Given this list of marker genes POLR2D, GTF2H1, POLR2A, GTF2H2, CDK7, GTF2F1, SUPT5H, GTF2F2, RNMT, MNAT1, CCNH, POLR2L, ERCC2, POLR2K (NCBI Gene Id 5440), NCBP1, GTF2H3, POLR2C, RNGTT, ERCC3, POLR2E (RNA polymerase II, I and III subunit E), POLR2J, GTF2H4, POLR2B, POLR2H, POLR2G, POLR2I (NCBI Gene Id 5438), NCBP2, GTF2H5, POLR2F (NCBI Gene Id 5435), here is a description of the gene set: The 5'-ends of all eukaryotic pre-mRNAs studied thus far are converted to cap structures. The cap is thought to influence splicing of the first intron, and is bound by 'cap-binding' proteins, CBP80 and CBP20, in the nucleus. The cap is important for translation initiation, and it also interacts with the poly(A)terminus, via proteins, resulting in circularization of the mRNA to facilitate multiple rounds of translation. The cap is also important for mRNA stability, protecting it from 5' to 3' nucleases, and is required for mRNA export to the cytoplasm.<BR>The capping reaction usually occurs very rapidly on nascent transcripts; after the synthesis of only a few nucleotides by RNA polymerase II. The capping reaction involves the conversion of the 5'-end of the nascent transcript from a triphosphate to a diphosphate by a RNA 5'-triphosphatase, followed by the addition of a guanosine monophosphate by the mRNA guanylyltransferase, to form a 5'-5'-triphosphate linkage. This cap is then methylated by 2'-O-methyltransferases.<P> part of: Metabolism of RNA Reactome Pathway: mRNA Capping species: Homo sapiens